The following is a description of a gene set: Human Gene Set: HP_ABNORMAL_NEUTROPHIL_PHYSIOLOGY species: Homo sapiens Any functional abnormality of neutrophils. Abnormal neutrophil physiology, and this is the list of marker genes: PMM2, NCF2, CYBC1, EFL1, CYBB, NCF1, SBDS, IRF8, SLC35C1, SPPL2A, RAC2, DNAJC21, CYBA, LCP2, GPI, CEBPE, LYST